The following is a description of a gene set: studied in species Mus musculus Mouse Gene Set: MIR_7039_5P Genes predicted to be targets of miRBase v22 microRNA mmu_miR_7039_5p in miRDB v6.0 with MirTarget v4 prediction scores > 80 (high confidence targets). from publication Chen Y, Wang X (PMID 31504780), and this is the list of marker genes: Fam216b, Vmn2r89, Eif5a2, Pak3, Heca, Xlr3b, Mfsd4b5, Ubtd1, Ripor2, Zfp583, Shisa6, Hebp1, Patj, Atp1b2, Ccdc121rt1, Cryba1, Hoxb9, Rspry1, Zfp738, Ankrd34c, Fam120a, Zfp11, Rxra, Lypd10, Zfp180, Ing5, Klk4, Flrt2, Alcam, Klf8, Psd4, 2210408I21Rik, 1500009L16Rik, Lurap1, Apbb3, Cd177, Lypd11, Nfasc, Jazf1, Ahcy, Grip1, Nhsl1